Given this list of marker genes GSTZ1, MCEE, THAP4, MYH4 (NCBI Gene Id 4622), TXNDC5, RPUSD4, DCT, DDX43, RANBP2, HSPD1, FKBP10 (NCBI Gene Id 60681), KIF20A, TTF2, KIF19, QSOX1, MYL6, CHD4, FKBP9, FKBP5, KIF16B, DYNLRB1, EIF4A1, PGM5, FKBP7, KIF15, PGM2, P4HB, PGM3, CHD1L, TBXAS1, POLQ, G3BP1, RTEL1, RECQL5, PPIAL4H, AQR, IGHMBP2, SUPV3L1, CHTF8, MYO10, PPWD1, DDX27, MCM7, BPGM, SLFN11, PDIA5, PTGES3, DDX41, HYI, FKBP2 (NCBI Gene Id 2286), PUS3, DNAH17, QSOX2, TRUB1, MYO1D, GNPDA2, KIFC3, RAD54L, PTPA, PPIH, DDX10, DDX47, HPGDS, KIF24, HELB, PPIAL4E, TNNT2, KIF2B, DDX54, CHD7, CYP2S1, DDX19B, HLTF, RUVBL1, DHX9, DHRS9, DHX37, KIF3A, DHX33, KIF20B, MYO5C (myosin VC), DNA2, RAD54L2, KIFC2 (NCBI Gene Id 90990), FAHD2A, KIF17, RPEL1 (ribulose-5-phosphate-3-epimerase like 1), MYO15A, DNAH3, PGAM1, RAD54B, DDX59, DDX39A, ALOX12B, DDT, ERCC6L, KATNA1, DDX17, MYH14, DDX4, KIF28P, DDTL, DHX32, ERCC6L2, PSMC4, FKBP6, MYH15, ITPK1, SNRNP200, HELQ, HELZ2, PDIA6, PIN4, IDI1, DNAI2, MOV10, DDX3Y, KIF5C, PGAM4, PSMC6, IDI2, EIF4H, MPI, FBH1, KIF18A, NAXE, EP400, FKBP1C, PUS7, RPUSD2, MYO1H, KIF12, RENBP, EBPL, DDX49, CHD6, KIF3B, BTAF1, HFM1, BRIP1, DHX36, CWC27, DNAH6, ECI1, DSCC1, SETX, MYO9A, TMEM86B, DDX11L8, PDIA3, RUVBL2, DHX8, MYH7, CENPE, PDIA4, KIF1B, ERCC3, FKBP1B, FKBP15, KIF2A, PGAM2, FIGNL1, PTGDS, YJEFN3, DDX52, DDX31, DEGS1, TOP3A, SHPRH, DDX28, KIF25, KIF22, DYNC1I1, CHTF18 (NCBI Gene Id 64722), STARD9, DDX20, MYO1E, DDX46, DHX40, PSMC2, DDX56, GALE, KIF7, ERP29, KIF13A, MYO1G, PIF1, FKBP4, DNAH5, FKBP8, EBP, DNAH1, MCM2, DKC1, CFTR, PMM2, KIF1A, DYNC1H1, SMARCA5, DDX5, PPIL1, KATNAL2, ATRX, GFUS, PBLD, DNAH9 (NCBI Gene Id 8709), MMUT, GSTA1, MYO1C, ASCC3, ACTC1, HSD3B1, MCM6, DHX57, PPIAL4F, TMX3, ISYNA1, ALOXE3, GLRX2, RECQL, RPE65, DHX30, DNHD1, MCM5, PUS7L, DHX15, RAD50, PDILT, PSMC1, SKIC2, KIF11, DICER1, FKBP11, DNAH2, PPIL6, ECHS1, PPIL2, SPO11, ERCC6, MOV10L1, RPE, PPIL4, EIF4B, TP53, MYO1B, FKBP3, ERP44, MYO9B, IQCA1L, RPUSD1, FAHD1, MYH7B, TDRD9, MCM4, PPIAL4G, ERP27, AIPL1 (aryl hydrocarbon receptor interacting protein like 1), FUOM, MIF, DDX55, RECQL4, DNAH7, GNPDA1, TOP1MT, APPBP2, PPIC, HELLS, PUS10, AMACR, PPIAL4C, GNE, SRCAP, MYH6, PPIB, CRELD2, DNAH8, DDX50, TRUB2, GALM, MYO3B, DDX24, PPIA, SMARCA4, MYH13, DDX21, FANCM, FMR1, PPIAL4D, IQCA1, CHD9, MYO7A, FAHD2B (NCBI Gene Id 151313), KIF9, DDX25, FKBP1A (NCBI Gene Id 2280), PGM2L1, ZNFX1, TOP3B (DNA topoisomerase III beta), NKTR, CHD3, RIGI, PTGES2, MYH2, PDIA2, MYO6, PPIF, KIFC1, DDX19A, MYH11, DHX58, CYP2J2, MYO1F, DYNC1I2, PPIAL4A, TDRD12, PTGIS, MYH8, MCM8, KATNAL1 (katanin catalytic subunit A1 like 1), KIF4A, CHD5, RFC4, WRN, PTGES, ECI2, KIF14, PPIL3, DDX23, FIGNL2, UPF1, SPAST, MCM9, PSMC3, MYO7B, DNAH12, IFIH1, MRE11, WRNIP1, FXR1, DDX18, DSE, HSD3B2, KIF26A, DDX6, NAV2, MYO1A, RAD51, RFC3, DDX53, CHD2, KIF4B, DNAL4, GPI, KIF18B, ITGB3, TWNK, ECH1, DDX3X, MYH1, SMARCA1, HELZ, DDX1, PPIG, DDX12P, ZGRF1, DDX39B, DDX42, XRCC6, PPID, DYNC2H1, MRI1, PSMC5, ERCC2, PIN1, PMM1, RFC5, RFC2, MYO3A, EIF4A2, BLM, PGM1, ZRANB3, TOP2B, DHX35, KIF13B, DNAH11, TOP2A, DHX16, DNAH10, PUSL1, FIGN, ENOX1, MYH10, KIF21B, RPIA, MTREX, KIF27, EIF4A3, TMX1, GLCE, EHHADH, RPUSD3, HSD17B4, MYH9, DSEL, YTHDC2, TOP1, DDX51, DDX60, L3HYPDH, MYH3, MYO19, KIF6, DYNLRB2, DHX38, DDX11, KIF26B, AIP, ENOSF1, SMC3, TPI1, PUS1, KIF2C, MCM3, KIF21A, LSS, KIF5B (kinesin family member 5B), MYO5B, PPIE, KIF5A, KIF3C, MYO5A, DQX1, SREBF2, CRELD1, SRR, DHX34, CHD1, KIF23, DNAH14, CHD8, XRCC5, DHX29, SMARCAL1, KIF1C, SDSL, SMARCAD1, SMARCA2, FKBP14, DDX60L, here is a description of the gene set: species: Homo sapiens Catalysis of the geometric or structural changes within one molecule. Isomerase is the systematic name for any enzyme of EC class 5. Human Gene Set: GOMF_ISOMERASE_ACTIVITY